Given this list of marker genes DNAJC24, DPH6, DPH3P1 (NCBI Gene Id 140827), DPH1, DPH5, SETD3, DPH7, DPH3 (NCBI Gene Id 285381), DPH2, here is a description of the gene set: The modification of peptidyl-histidine. species: Homo sapiens Human Gene Set: GOBP_PEPTIDYL_HISTIDINE_MODIFICATION